Given this list of marker genes NOTCH3, ASPA, DNMT1, B4GALNT1, SOD1, FBLN1, ALDH18A1, ADSS1, PI4KA, ZFYVE26, NEFH, SEC31A, RARS1, ERLIN2, HMBS, PRPH, SPG7, GM2A, PUS3, TGM6, ACTB, ADGRG1, AP4M1, CYP27A1, ALS2, LMNB1, NUS1, DCTN1, HTRA1, FIG4 (NCBI Gene Id 9896), NONO, SRPX2, here is a description of the gene set: Pseudobulbar signs result from injury to an upper motor neuron lesion to the corticobulbar pathways in the pyramidal tract. Patients have difficulty chewing, swallowing and demonstrate slurred speech (often initial presentation) as well as abnormal behavioral symptoms such as inappropriate emotional outbursts of uncontrolled laughter or weeping etc. Human Gene Set: HP_PSEUDOBULBAR_SIGNS Pseudobulbar signs species: Homo sapiens